Given this list of marker genes AKT2, PDE3B, here is a description of the gene set: Reactome Pathway: PDE3B signalling studied in species Homo sapiens AKT (PKB) is recruited to the plasma membrane by binding phosphatidylinositol (3,4,5)-trisphosphate (PIP3). AKT is then activated by phosphorylation. Activated AKT in turn phosphorylates Phosphodiesterase 3B (PDE3B) which hydrolyzes 3',5'-cyclic AMP (cAMP). part of: PKB-mediated events